Given this list of marker genes PLA2G2A, PTGDS, CBR1, PTGS2 (prostaglandin-endoperoxide synthase 2), LTA4H, ALOX15, TGM2, DPEP1, GGT1, CBR3, PLA2G10, TBXAS1, ALOX5, PTGIS, ALOX15B, here is a description of the gene set: Eicosanoid metabolism. studied in species Homo sapiens Human Gene Set: MODULE_431